The following is a description of a gene set: studied in species Homo sapiens Most human cancers are characterized by genetic aberrations accompanied by altered expression and function of numerous genes. Applying genome-wide, microarray gene expression analysis to identify deregulated genes in different tumour types can provide potential gene candidates as diagnostic and prognostic tools and promising targets for drug development. However, the detection of deregulated genes with low levels of expression remains a major challenge. In this study, we have designed a strategy, termed modified suppression subtractive hybridization (mSSH), to identify genes encoding rare transcripts. The strategy entails incorporating the T(7)-promoter sequence at the 5' end of the noncoding cDNA strand during first strand cDNA synthesis to generate unidirectional antisense RNA from the resultant cDNA following conventional SSH. These transcripts are subsequently analysed by Affymetrix oligonucleotide gene arrays. Here, we have used five hepatocellular carcinoma (HCC), five breast carcinoma and four nasopharyngeal carcinoma (NPC) biopsies separately as testers and their corresponding normal biopsies as drivers to enrich for low abundance tumour type-specific transcripts. The total detectable number of probe sets following mSSH was reduced almost 10-fold in comparison to those detected for the same resected tumour tissues without undergoing subtraction, thus yielding a subtraction efficacy of over 90%. Using this experimental approach, we have identified 48 HCC-specific, 45 breast carcinoma-specific, and 83 NPC-specific genes. In addition, genes were upregulated in all the three cancer types. When compared to gene-profiling data obtained without mSSH, the majority of these identified transcripts were of low abundance in the original cancer tissues. mSSH can therefore serve as a comprehensive molecular strategy for pursuing functional genomic studies of human cancers. Low abundance transcripts common to nasopharyngeal carcinoma (NPC), breast and liver tumors. from publication Liu BH, Goh CH, Ooi LL, Hui KM (PMID 18332864) Human Gene Set: LIU_COMMON_CANCER_GENES, and this is the list of marker genes: MT-ND4, ATP8B1, SFTPB, ALMS1, SYNCRIP, ZNF252P, PDF, NOP56, UACA, TCF7, WRAP53, FGFR1, LRRFIP1, LARS1, ENSG00000229839, HAUS2, ANAPC16, ZNF160, OCIAD1, GTSE1, TMEM241, HSPE1, SERP1, CCDC152, GATAD2A, UBXN2A, DDX27 (DEAD-box helicase 27), ATF7IP, GPBP1, DDX59, TMBIM4, CPNE9, RPL41, PRDX2, COL11A2, LIMD1, ERC1, DAP3, TUBGCP2, NUMBL, PGF, B2M, NDUFS8, HNRNPDL, NSMCE2, DBT, ATP6V0A1, POLR1B, USP34, PDE4C, SCAMP2, PRR11, RAB11FIP1, ZNF611, UBE2D4, CDK13, ZC3H7B, PCLAF, SLC35E1, TLE1, F7, RPL34, SLFN5, INTS4